The following is a description of a gene set: The chemical reactions and pathways resulting in the formation of purine nucleobases, one of the two classes of nitrogen-containing ring compounds found in DNA and RNA, which include adenine and guanine. Human Gene Set: GOBP_PURINE_NUCLEOBASE_BIOSYNTHETIC_PROCESS studied in species Homo sapiens, and this is the list of marker genes: HPRT1, PRTFDC1, ADA, PAICS, APRT (adenine phosphoribosyltransferase), PRPS1 (phosphoribosyl pyrophosphate synthetase 1), SHMT1, GMPS, PPAT, GART